The following is a description of a gene set: species: Homo sapiens Human Gene Set: GOBP_MORPHOGENESIS_OF_AN_EPITHELIUM The process in which the anatomical structures of epithelia are generated and organized. An epithelium consists of closely packed cells arranged in one or more layers, that covers the outer surfaces of the body or lines any internal cavity or tube., and this is the list of marker genes: GNA13, MICAL2, ADAMTS12, CYP7B1, DLG1, SOX10 (NCBI Gene Id 8223), GDF2, CELSR1, PAFAH1B1, DCHS1, IL10, CCL11, STOX1, LGR5, WNK4, CA9, DVL1, PKD2 (polycystin 2, transient receptor potential cation channel), CCM2, BRD2, BBS5, PITX2, GREM1, ESRP2, NKX3-1, HOXB13, HAND1, STAT5A, EXT1, CSNK2B, EZR, DNAAF1, OPA1, FOXF1, HOXA11, CASR, FST, AR, RREB1, HES5, PAK1, MIR15B, NCKAP1 (NCBI Gene Id 9864), BTRC, NKD1, FRAS1, TGFB1, STAT1, LIAS, LUZP1, ALDH1A3, FLRT3, LHX2, CCDC103, ARHGAP12, EDNRA, LMO4, WDR1, HOXA13, OPHN1, LHX1, NKX2-1, FGFR2, SDC4, HHIP, ACTB, BRSK2, NTN1 (netrin 1), MIR221, VEGFA, RALA, FGF2, KAT2A, IRX2, DLX3, RHOB, PTK7, TEAD2, SOX9, SRF, WNT7A, DVL2, CCDC40 (coiled-coil domain 40 molecular ruler complex subunit), FREM2, IFT57, PLOD3, PRICKLE1, SNAI1, RBM15, TBX2, FOXD1, WNT11, KIF26B, MSN, MTSS1, MYCN, SCRIB, HBEGF, MTOR, GLI2, ID4 (NCBI Gene Id 3400), GCM1, ACVRL1, WNT9B, WNT3A, NOTCH4, LRG1, SMAD3, DAG1, NHERF1, SPECC1L, SNAI2, CASP3, ITGAX, HNF1B, TMEM59L (transmembrane protein 59 like), NPHP1, VANGL2, COL5A1, FEM1B, CITED1, CSMD1, GBX2, ASB2, HOXB2, AGTR2, PTEN, PHACTR4, ZDHHC7, TBX4, SOS1 (SOS Ras/Rac guanine nucleotide exchange factor 1), IRX3, TACSTD2, MEF2C (NCBI Gene Id 4208), LBX2, CARMIL2, AGT (NCBI Gene Id 183), PML, SIX1, FRS2, CLASP1, C1orf54, IFT122, ITGAV, GJA1 (NCBI Gene Id 7953), FOXF2, ST14 (ST14 transmembrane serine protease matriptase), RPS7, PPP3R1, CTSH, KIF20B, LCP1, RNF207, YAP1, LIN7C, GRB2, KLK14, KRT71, BCL10, RSPO2, RIPK4, TGFBR2, MTHFD1, GREB1, TTC8, MDK, EGFR, PTCH1, GATA3, SEMA3C, CTSZ, WNT5B, NTN4, GDNF, VASP, TFAP2A, CDC42, FGFR1, APLNR, GREB1L, DLC1, JHY, CSF1, TSC1, WNT5A, SH3BP1, KRT6A, PPP1CA, FOXH1, BMP7, BBS4, NOTCH1, GORAB, TRAF6, WDR83, FOLR1, PGR (NCBI Gene Id 5241), SKI, PLXND1, CTNNBIP1, WT1, ADAMTS16, KRT12, WNT6, PRKACB, FOXA1, LEF1, GLMN, PAX8, FOXN4 (NCBI Gene Id 121643), TMEM79, WNT2B, SLC39A12, MMP14, ZEB2, BSG, GLI3, RHOA, FOXN1, TOR1A, PLXNB2, ADM, MIR21, DLL4, TIMELESS, EPHA2, WNT1, KRT25, SYNE4, FOXP1, HMGA2, SALL4 (NCBI Gene Id 57167), PODXL, PDCD10, FLNA, TNC, TCF15, TCF21, VEGFC, MKKS, HOXD11, HTN1, LCN2, PKD1 (polycystin 1, transient receptor potential channel interacting), HS2ST1, SEC24B, GRHL2, NOTCH2, PSEN1, JAG2, STARD13 (NCBI Gene Id 90627), ALDH1A2, TRAF3IP1, CLUAP1, PBX1, SERPINB5, HOXD13, TGFB1I1, NPHP3, KDF1 (keratinocyte differentiation factor 1), RHOC, NAGLU (NCBI Gene Id 4669), FERMT2, RARG, FIGNL2, CLIC4, SOX18, AREG, KDR, TRIM28, PHLDB2, GDF7, IGF1, HAND2, GPC3, PCDH8, HS3ST3B1, MET, RARA, SFRP2, TGM3 (transglutaminase 3), CXCL10, EPB41L5, NODAL, PDGFA, SULF1, RET, STIL, GRSF1, KRT28, DSC1, MMRN2, CEP290, TWIST1, FERMT1, CTNND1, SALL1, CC2D2A, CCDC39, PDX1, VDR, LRP2, TRIM71, ACTG1, DLG3, SHH, SOSTDC1, FRZB, KLF4, FGF1 (fibroblast growth factor 1), SOCS3, ILK, NR3C1, PKHD1, IGFBP5, SETDB2, BCL2, SMAD4, ITGB5, SOX11, TGM2, HOXB4, RPGRIP1L, RAP2A, LAMA5, PERP, TSC2, SUFU, NOG, FOXE1, ACVR1, RSPO3, DLG5, SPRY2, CD151, VCL, CFL1 (NCBI Gene Id 1072), ARL13B, IFT172, FZD5, HOXB7, SLIT2, PROX1, PIK3CD, MIB1, TNF, MRTFA, WNT2, NKX2-5, MAGED1, SEMA3E, TCAP, MIR16-1 (NCBI Gene Id 406950), TULP3, TGIF1, NUP50, ITGB1, ABL1, NOTO, GZF1, TBX3, IFT52, GATA4, RASIP1 (Ras interacting protein 1), TBX5, ESR1 (NCBI Gene Id 2099), BMP5, DDR1 (NCBI Gene Id 780), SIRT6, HGF (hepatocyte growth factor), KDM5B, FGF7, PALS1, TMED2, RBPJ, RDH10, ASTN2, ZIC3, EYA1, SPINT1, MKS1, IRX1, CTNNB1 (catenin beta 1), WDPCP, FZD3, ARHGAP24, OSR1, CAMSAP3, TBX18, COBL, HESX1, MSX2, APAF1, MESP1, C2CD3, JAG1, FKBPL, KRT27 (NCBI Gene Id 342574), NFATC4, DEAF1, SOX17, LLGL2, MMP2, GRHL3, EPHA4, TMEFF2, BRSK1, SIX4, EGF, LIF, ENG, HIF1A, BTBD7, MED12, AIRE, FUZ (NCBI Gene Id 80199), PRKACA, CDK20, STK4, CD44, WNT16, MTHFR, ATP7A, TCTN1, IHH, TP63, FOXQ1, PFN1, NPNT, PDPN, AJAP1, INTU, SPRY1, MEGF8, BBS7, TBX20, WNT10A, KRT16, PLET1, RYR2, HS3ST3A1, SEMA4C, LAMA1, KRT17, FGF10, CLASP2, KRAS, EXOC5, WNT4, MTHFD1L, FOXC2, PAX2, SFRP1, ITGA5 (NCBI Gene Id 3678), PHB2, CTHRC1, FZD6, RGMA, OVOL2, HOXA5, HES1, ALX1, IFT20, CITED2, BMP2, LGR4, NGFR, ERBB4, TFAP2C, ADAM17, EDN1, NRARP, SPINT2, CEACAM1, BMP4, CRYGS, SOX8, ARHGAP35, SMO, COL4A1, CAV3, PRKD2, EPHA7, DLL1, PRKX (protein kinase cAMP-dependent X-linked catalytic subunit), AJUBA, WNT7B (NCBI Gene Id 7477), KDM2B, RAB10, ETV5, SRC, FLG2, MMP12, TIE1, STK3, PLA2G10, EFNB2, ITGB3, PLXNA1, FGF8, NRP1, LBX1, CA2, NDRG4, MYO9A, CECR2, SIX2, MED1, FAT1, MYC, CSF1R, SAPCD2, LRP5, TGFB2, KLHL3, LZTS2, AHI1